Given this list of marker genes RPL36, SLC15A1, DAGLB, TRIM15, RRN3P1, MB, DVL2, TNFRSF12A, C6orf141, MTO1, RND1, QSER1, LAMP1, CROCCP3, MED21, HAPLN2, COQ10A, NOL6, TTC1, MTFMT, ADA, SNHG30, AGMAT, FES (NCBI Gene Id 2242), here is a description of the gene set: Genes containing one or more binding sites for (ZNF292) in their promoter regions (TSS -1000,+100 bp) as identified by GTRD version 20.06 ChIP-seq harmonization. Human Gene Set: ZNF292_TARGET_GENES from publication Yevshin I, Sharipov R, Kolmykov S, Kondrakhin Y, Kolpakov F (PMID 30445619) studied in species Homo sapiens